Given this list of marker genes Ugt1a7c, Trpv4, Pdlim5, Cask, Nell1, Sdc4, Hdac5, Ldb3, Cavin2, Dact2, Prkcsh, Rack1, Dact1, Cavin3, Itgb3, Plek, Pkn1, Irs1, Add3, Dact3, Sqstm1, Pea15a, Hspb1, Slc22a8, Top2a, Twf2, Prkd2, Prkcb, Fez1, Glrx3, Abl1, Adcy6, Ccdc88a, Dsp, Ywhag, Adcy4, Tirap, Flna, Pkp2, Akt3, Ugt1a8, Adam9 (ADAM metallopeptidase domain 9), Marcks (NCBI Gene Id 17118), Rbck1, Itgav, Pld2, Ugt1a9, Copb2, Srsf2, Hdac7, Casq2, Src, Akt2, Hdac9, Akt1, Ugt1a10, Nell2, Pick1, Pawr, Prkd1, Tdg, C1qbp, here is a description of the gene set: Mouse Gene Set: GOMF_PROTEIN_KINASE_C_BINDING species: Mus musculus Binding to protein kinase C.